The following is a description of a gene set: species: Homo sapiens Human Gene Set: GOMF_TORC2_COMPLEX_BINDING Binding to a TORC2 complex., and this is the list of marker genes: AKT1, SIRT6, NCKAP1L, RPL23A, ARMH4